The following is a description of a gene set: Human Gene Set: CREIGHTON_ENDOCRINE_THERAPY_RESISTANCE_4 from publication Creighton CJ, Massarweh S, Huang S, Tsimelzon A, Hilsenbeck SG, Osborne CK, Shou J, Malorni L, Schiff R (PMID 18794137) species: Homo sapiens The effectiveness of therapies targeting specific pathways in breast cancer, such as the estrogen receptor or HER2, is limited because many tumors manifest resistance, either de novo or acquired, during the course of treatment. To investigate molecular mechanisms of resistance, we used two xenograft models of estrogen receptor-positive (ER+) breast cancer, one with and one without HER2 overexpression (MCF7/HER2-18 and MCF7 wt, respectively). Mice with established tumors were assigned to the following treatment groups: estrogen supplementation (E2), estrogen deprivation (ED), ED plus tamoxifen (Tam), all with or without the epidermal growth factor receptor tyrosine kinase inhibitor gefitinib (G). Another group received ED plus the antiestrogen fulvestrant (MCF7 wt only). Tumors with acquired or de novo resistance to these endocrine therapies were profiled for gene expression and compared with tumors in the E2 control group. One class of genes underexpressed in endocrine-resistant tumors (relative to E2-treated tumors) were estrogen inducible in vitro and associated with ER+ human breast cancers (luminal subtype). Another class of genes overexpressed in tumors with acquired resistance in both models represented transcriptional targets of HER2 signaling and was associated with ER-/HER2+ human cancers (ERBB2+ subtype). A third class of genes overexpressed in MCF7/HER2-18 tumors exhibiting de novo resistance to tamoxifen was associated with ER+ human cancers but not with estrogen-regulated genes. Thus, in response to various endocrine therapy regimens, these xenograft breast tumors shut down classic estrogen signaling and activate alternative pathways such as HER2 that contribute to treatment resistance. Over time, the molecular phenotype of breast cancer can change. The 'group 4 set' of genes associated with acquired endocrine therapy resistance in breast tumors expressing ESR1 but not ERBB2., and this is the list of marker genes: ADAMTS19, SNHG14 (NCBI Gene Id 104472715), COL4A5, RPL28, BAG3, VCAN (NCBI Gene Id 7902), RMST, RPRD1A, TIPARP, PSMG1, SKIC3, POLR1D, KRTCAP3 (NCBI Gene Id 200634), SLC22A5, LRIG1, PUS1, SLC26A2, ADD3, RASA4, CXCL12, HPGD, EMP3, PKIB, PI15, LRWD1, PSMF1, PDZK1 (NCBI Gene Id 96133), HNMT, GNPDA1, SIAH2-AS1, ABAT, P4HA2, PRRT2, BYSL, ATP8B1-AS1, SUSD3, AFF1, COX6CP1, MRC2 (NCBI Gene Id 9902), RAB11FIP3, METTL14, SIK3, SFPQ, MED13L, SINHCAF, CEP68, SYTL4, ADORA1 (adenosine A1 receptor), SGK3, PPP2R5A, SERPINA5 (serpin family A member 5), TP53I3, CDV3, IL27RA, HAUS6, SLC27A3, COPS9, TMEM164, DLG5, SLC27A2, ZBTB41, ELOVL5, HMGN3, MSI2, MIR503HG, RERG, CALHM6, IL24, ATRNL1, ASS1, TSPYL5, NLN, FYB2, CYP1B1, MRPL9, LYSMD2, SAP30 (NCBI Gene Id 8819), FTO, MYB, SIAH2, FDFT1, RHBDF2 (rhomboid 5 homolog 2), EMC8, KIF20A, APH1B (aph-1 homolog B, gamma-secretase subunit), RGS22, FOXK2, TCN1, NREP, SYBU, SRGAP1, EMP2, TPP1, KAT2A (NCBI Gene Id 2648), SCUBE2, FGD3, KCTD6, DVL2, LYRM4, MAPT, FRK, LYAR, SRSF7, GLS, FGFBP2, CA12, RFX5, NPY1R, APEX1, COA4, FANCG, DOK7, TPBG, FLNB, HR, SH3BP5, NOS1AP, IL20, METTL5, PDCD4, PARP4 (NCBI Gene Id 221181), LINC01016, POLR1E, ADGRE5, RPH3AL, STC1, APTX, MGP, FREM2, SAV1, RNF183, RBM33, FOXO3, SLC25A22, CADM1, CBX2, IL17RB, ZNF703, SPART, AMFR, DPY30, MYO16, CELSR2, LINC01116, PPP1R7, NT5DC3, NPY5R, TMPRSS3, PRSS23, MEX3A, SPARC, RUVBL2, XYLT1, BHLHE40, MOCS2, LSM6, CHN1, COX15 (NCBI Gene Id 1355), GTPBP8, SLC27A6, MYBL1, TST, ITGA2, PIK3R1, BOD1 (NCBI Gene Id 91272), NAF1, LYPLAL1 (lysophospholipase like 1), MT2A, F12, FGG, CYB5A (NCBI Gene Id 1528), NPEPPS, RFXANK, IRS1, PCBD2, PLAC1, COX6C, HSPA4, TBL1X, STMN3, DHTKD1, SYTL5, JARID2, PDLIM1, TIMM9, TSKU, RBMX, C2orf49, IGF1R, TAF1D, EHMT2, ATP2B4, SLC19A2, RBBP8, LARGE1 (LARGE xylosyl- and glucuronyltransferase 1), TRIM69, SMPDL3B, MYC, IRS2 (insulin receptor substrate 2), C12orf75, DDX11-AS1, ADCY9, MPPED2, GRIK3, ELOVL2, RPL7AP10, YBX3, COPRS, ADCK2, NRXN3 (NCBI Gene Id 9369), NOP14, TUBB2B, CCNA1, PRKD3, AK4, GSTO1, TFAP2C, PNMA1, HDHD5, SULF1, UTP14C, BCL2, MED24, DFFA, H19, AFAP1L2, LINC00342, BBIP1, MAD2L2 (NCBI Gene Id 10459), DSCAM, ADAMTS15, RAB31, GREB1, MDH2, RPP25L, ELP2, CCNB1, PGR, DLC1, KPNB1, RAP2C, SIMC1, GATD3, DUXAP8, KCNMB4 (NCBI Gene Id 27345), EGR3, TECR, NSA2, GNB4, RHOBTB3, SLC37A4, SNTG2-AS1, SLC25A24, ZNF385B, JADE1, SSTR2, SEMA3F (NCBI Gene Id 7868), MAGED4B, OLFM1, SRI, FCMR, CPE, SERPINA3, RHOQ, CALCR, RBM24, KCNJ3 (NCBI Gene Id 3760), PMAIP1 (phorbol-12-myristate-13-acetate-induced protein 1), ELP5, DUBR, SIGMAR1, ZHX2, TARS2, CIART, DHCR7, FKBP5, TMEM167A, HSPB8, RPS6KA3, ARHGAP36, FAM227B, CALB2, TNIP1, TTC39A, LAGE3, COL5A1, PNPLA3, HPCAL1, SLC1A4, ST8SIA4, PRMT5, LAMP2, MAVS, IGSF1, TUBB6, C1orf226 (NCBI Gene Id 650140), IRX3, SERTAD2, PARD6B, RRP1B, PAPSS2, PLIN5, SLC7A6OS, SKP2, TSPAN6, BMPER, NRIP1